The following is a description of a gene set: Mouse Gene Set: GOMF_RNA_POLYMERASE_II_CTD_HEPTAPEPTIDE_REPEAT_KINASE_ACTIVITY studied in species Mus musculus Catalysis of the reaction: ATP + RNA polymerase II large subunit CTD heptapeptide repeat (consensus YSPTSPS) = ADP + H+ + phosphorylated RNA polymerase II., and this is the list of marker genes: Ccnk, Mapk1, Cdk8, Cdk13, Cdk9, Brd4, Cdk1, Cdk7, Dyrk1a, Cdk12